The following is a description of a gene set: studied in species Homo sapiens part of: Metabolism of amino acids and derivatives Catecholamines and thyroxine are synthesized from tyrosine, and serotonin and melatonin from tryptophan. Reactome Pathway: Metabolism of amine-derived hormones, and this is the list of marker genes: DIO3 (iodothyronine deiodinase 3), TSHB, DUOXA1, TPH1, CGA, IYD, DUOX2, DDC, DIO1, TXNDC11 (NCBI Gene Id 96770), DBH, SLC5A5, DIO2, ASMT, TPH2, TH, AANAT, CAV1, TPO, PNMT, DUOXA2, DUOX1